The following is a description of a gene set: studied in species Homo sapiens Irregular dentition Human Gene Set: HP_IRREGULAR_DENTITION, and this is the list of marker genes: DCHS1, NFIX, FAT4, SOX9, RIN2, NMNAT1